The following is a description of a gene set: The chemical reactions and pathways involving steroids, compounds with a 1,2,cyclopentanoperhydrophenanthrene nucleus. studied in species Mus musculus Mouse Gene Set: GOBP_STEROID_METABOLIC_PROCESS, and this is the list of marker genes: Lhcgr, Insig2, Ugt2b38, Adm, Hsd17b12, Sult2a5 (sulfotransferase family 2A, dehydroepiandrosterone (DHEA)-preferring, member 5), Hsd17b10, Apobr, Cyb5r2, Aplp2, Sec14l2, 2610005L07Rik, Ddx20, Hrh1, Sult1a1, Il4, Nr0b1 (NCBI Gene Id 11614), Pip4p1 (NCBI Gene Id 219024), Mapk1, Hint2, Prox1, Erg28, Fgfr4, Lpcat3, Cmtm2a, Cyp46a1, Akr1d1, Ces1g, Cyp2d22, Sult2a1, Esr1, Crh, Bmp6, Hsd3b1, Lima1, Gba1, Sts, Pctp, Sirt1, Ebp, Acox2, Gnb3, Hsd17b14, Hmgcr, 3110082I17Rik, Lrp1, Fabp6, Acadl, Vldlr, Srd5a2, Baat (bile acid-Coenzyme A: amino acid N-acyltransferase), Cyp2b13, Srebf1, Lipo4, Cyp1a2, Malrd1, Rdh1, Abcd3, Mbtps2, Cyp11b2, Rdh16, Acbd3, Tnfsf4, Amacr, Gh, Fech, Prkaca, Cyp2r1, Faxdc2, Cln8, Cat, Nfkb1, Soat2, Slc27a5 (NCBI Gene Id 26459), Arv1, Prkg1, Lss, Acadvl (NCBI Gene Id 11370), Serpina6, Hsd17b4, Sult2a8, Cyp3a44, Akr1c12, Ldlrap1 (NCBI Gene Id 230816), Ppargc1a, Bglap, Ugt2b37, Ugt2b5, Rdh5, Snai2, Fgf15, Dhrs4, Gprc6a, Hnf1a, Enpp1, App, Cyp2b9, Igf1r, Sult2a6, Aqp8, Akr1c14, Nr3c1, Fgl1, Paqr3, Idi1, Mbtps1, Med1, Cebpa, Thrb, Ces1d, Cubn, Idi2, Plekha1, Cbr1b, Dhh, Rora, Stat5b, Cyp27b1, Hsd3b7, Mecp2, Tspo, Gal, Sdr42e1, Gba2, Cyp2b23 (cytochrome P450, family 2, subfamily b, polypeptide 23), Schip1, Sult2a2, Creb1, Comt, Serpina12, Cacna1h, Rdh9, Bglap2, Mttp, Nsdhl, Nr5a2, Apof, Gm2044, Cyp3a11, Ces1b, Pde8b, Ednrb, Dkk3, Tiparp, Cyp24a1 (NCBI Gene Id 13081), Rorc, Cga, Npc1, Npy1r, Akr1cl, Cyp3a16, Cyp3a57, Hsd17b1, Pcsk9, Cyp27a1, Abcg1, Abcg4, Gpr146, Pmvk, Dgat2, Cln6, Kcnma1, Mvk, Cyp11a1 (NCBI Gene Id 56432), Cbr1, Cftr, Lipe, Akr1c18, Cyp2b19, Hmgcs2, Pmp22, Dgkq, Scp2, Atp1a1, Bmp5, Tnf, Igfbp7, Fdps, Angptl3, Hsd3b3, Slco1a6, Erlin1, G6pd2, Nr1h4, Sult1e1, Cyp17a1, Hmgcs1, Pbx1, Cyp19a1, Ugt2b1, Akr1c20, Lipa (NCBI Gene Id 16889), Prkaa1, Dkkl1, Ttc39d, Tm7sf2, Abca5, Bmpr1b (NCBI Gene Id 99865), Gm8978, Bmp2, Insig1, Ugt1a7c, Akr1c21, Lrp2, Bdh1, Stard4, Sod1 (NCBI Gene Id 319325), Cyp2b10, Slc37a4, Fdxr, Mvd, Hsd3b6, Armc5, Ces1c, Ces1e, Apon, Apoa5, Nfe2l1, Sult2a7, Ggcx, Apoa1, Chst10, Akr1c6, Apoe, Smpd1, Hsd17b6, Ch25h, Dhcr7, Stat5a, Hdlbp, Apoc1, Gnai1, Cyb5r1, Cyp3a13, Ces1f, Qki (NCBI Gene Id 66145, quaking, KH domain containing RNA binding), Sult4a1, Foxa2, Sc5d, Scnn1b, Snai1, Acaa1b, Slc27a2, Gfi1, H6pd, Disp3, Lipo3, Hsd3b4, Kit, Stard3, Rdh19 (retinol dehydrogenase 19), Ebpl, Sult2a3, Gc, Akr1c19, Star, Pank2, Cyb5r3, Cyp51, Cyp8b1, Pex2, Ldlr, Il1a, Adora2b, Fgfr1, Apoc3 (NCBI Gene Id 11814), Asah1, Ifng, Wnt4, Errfi1, G6pdx, Sult2a4, Hsd11b2, Lipo1, Por, Ces1h, Npc1l1, Atp8b1, Hsd11b1, Rdh16f2, Nr1d1, Ugt2b36, Erlin2, Hsd17b8, Cyp7a1, Hsd17b3, Dhrs9, Tsku, Ephx2, Afp, Sqle, Sf1, Fdft1, Fmo5, Cyp3a41a, G6pc1, Cyp3a59, Hsd3b2, Akr1c13, Cyp1b1, Npc2, Ugt2b35, Tecr (trans-2,3-enoyl-CoA reductase), Abcc1, Pdgfra, Srebf2, Cyp2e1, Ugt2a1, Lep, Shh, Cyp3a41b, Srd5a1, Msmo1, Igf1, Inhba, Hsd17b11, Hsd17b7, Ces1a, Fgf1, Saa1, Scap, Abca1, Ywhah, Pon1, Abcb11, Dhcr24, Lepr, Fshb (NCBI Gene Id 14308), Sgpl1, Sult2b1 (NCBI Gene Id 545963), Cyp7b1, Hsd3b9, Cyp11b1, Cyp1a1, Ttc39b, Igf2, Lbr, Fdx1, Lrp5, Fgf23, Dab2 (NCBI Gene Id 70555), Apoa4, Cyp39a1, Hsd3b5, Prkaa2, Apoa2, Abca2, Dhrs11, Spp1, Hsd17b2, Ugt1a1, Lmf1, Acaa1a, Lipo2, Ugt2a2, Clcn2, Stub1, Rdh7, Lcat, Scarb1, Egr1 (early growth response 1), Lipc, Sdr9c7, Soat1 (sterol O-acyltransferase 1), Rest, Apob, Cyp21a1, Hsd3b8, Cyp3a25